The following is a description of a gene set: Genes predicted to be targets of miRBase v22 microRNA hsa-miR-654-3p in miRDB v6.0 with MirTarget v4 prediction scores > 80 (high confidence targets). studied in species Homo sapiens from publication Chen Y, Wang X (PMID 31504780) Human Gene Set: MIR654_3P, and this is the list of marker genes: RDX, AIG1, PCDHB13, LHFPL6 (LHFPL tetraspan subfamily member 6), DHODH, AGAP1, CYP4B1, RBM41, PAFAH1B1, MR1, QRICH1, PTPRS (NCBI Gene Id 5802), NRXN1, GLRA2, CEP97, PACSIN1, PHIP, PLK4, SLC4A10, JAZF1, AP1G1, ZCCHC10, WDSUB1, AGMAT, SLC16A1, PCDH7, KLF12, LRP8, KCNV1, FUNDC2, MCTS1, ING3, WASHC4, OSBPL8, CENPI, HAUS6, HDGF, C2orf69, TANK, DCDC2, CLGN (NCBI Gene Id 1047), PGBD1, ZNF91 (NCBI Gene Id 7644), CEP128, POU4F2, PUDP, RNF145, PLCXD3, SNTB1, TMPRSS15 (transmembrane serine protease 15), ATP2A2, ASH1L, PLLP, B3GAT1, GMFB, RFXAP, LRCH3, NETO1, LCE5A, ZNF75D, ZNF100, ILDR2, MB21D2, STX11, RBMS2, COLEC12, SORBS1, MARF1 (meiosis regulator and mRNA stability factor 1), ITCH, BCKDHB, ZNF728, PAPPA, PCDH17, RICTOR, ANKRD30A, SPX (spexin hormone), CCDC148, SNAPIN, EMP1, SIPA1L2, TNIP3